The following is a description of a gene set: studied in species Homo sapiens Human Gene Set: GOBP_MAMMARY_GLAND_INVOLUTION The tissue remodeling that removes differentiated mammary epithelia during weaning., and this is the list of marker genes: CDKN2A, IGFBP5, BAX, VDR, ELF3, BSX, CAPN1, PML, CAV1 (caveolin 1), NFKB1